The following is a description of a gene set: from publication Denning TL, Wang YC, Patel SR, Williams IR, Pulendran B (PMID 17873879) Human Gene Set: GSE8868_SPLEEN_VS_INTESTINE_CD11B_POS_CD11C_NEG_DC_UP species: Homo sapiens Genes up-regulated in dendritic cells (DC) from spleen versus those from intestine. The intestinal immune system must elicit robust immunity against harmful pathogens but restrain immune responses directed against commensal microbes and dietary antigens. The mechanisms that maintain this dichotomy are poorly understood. Here we describe a population of CD11b+F4/80+CD11c– macrophages in the lamina propria (LP) that express several anti-inflammatory molecules including interleukin 10 (IL-10), but little or no pro-inflammatory cytokines, even upon stimulation with Toll-like receptor (TLR) ligands. These macrophages induced, in a manner dependent on IL-10, retinoic acid and exogenous transforming growth factor-β, differentiation of FoxP3+ regulatory T cells. In contrast, LP CD11b+ dendritic cells elicited IL-17 production. This IL-17 production was suppressed by LP macrophages, indicating that a dynamic interplay between these subsets may influence the balance between immune activation and tolerance. Splenic or small intestine lamina propria CD11b+11c- cells were isolated for RNA extraction and hybridization on Affymetrix microarrays. We sought to determine the unique genetic profile of small intestine lamina propria CD11b+11c- cells., and this is the list of marker genes: RNF181, ATXN3, MCEMP1, B3GNT2, USP3, MFSD14A (major facilitator superfamily domain containing 14A), PGLYRP1, NAAA, KLHL25, RAB5IF, RALGAPB, C11orf68, TADA1, PRKAB1, RIOX1, CAP1, WAPL, AP1M1, FKBP1B, TBPL1, MARK2, JAZF1, GRINA, CCDC28B, SERTAD3, SYNE3, LFNG, TSTD1, RABIF (NCBI Gene Id 5877), SH3GL1, SGK3, SENP7, PCIF1, GABARAPL2, LTB, BCL11A, ZBTB39, G6PD, RNF31, NFAM1, DENND11, EVI5, THSD1 (NCBI Gene Id 55901), POR, BPIFB3, CCDC125, SLC9A1, FOXD2, ZNF746, STAT5A, CBX8, RAB29, USF3, SATB2, C6orf118, SDCCAG8 (NCBI Gene Id 10806), INTS5, ESRP2, PYGL (glycogen phosphorylase L), AGAP2 (ArfGAP with GTPase domain, ankyrin repeat and PH domain 2), SVIP, SULF2, IREB2, SPSB4, SLC15A4, COL8A2, TSEN34, SLMAP, DAAM1, ZC3HAV1, CCDC146, TENT4B, ZNF414, NLRP12, LDHB, CBFA2T3, FRAT1, INPP5B, TRIM34, SUN1, MOB3A, LY75, GIGYF2, ZYX, PKP3, DDX41, ZBTB42, TIAM1, TMEM40, DKK4, PCED1B, ATG4D, MFSD14B, NSD3, FBXO45, ARFIP1, UGP2, DYNLL1, RGS2, MFSD6, FAM53C, SLC22A15, CMC2, KCTD20, PHETA2, MYO1F, SIK1, GSKIP, RNF114, FLNA, SLC2A3, NFE2, PCOLCE2, WTAP, EPX, C5orf34, CSRNP2, SNRK, RGS3, F8A1, ZBTB9, UBA3, ABRAXAS2, ITGB7, CELSR3, KANK3, NOP53, BRD7, RIOK3, PDF, MCTP2, NSMCE4A, VPS13B, JAM3 (junctional adhesion molecule 3), KCTD11, PPP4R3B, STX16, PLIN5 (perilipin 5), GDPGP1, ICAM2, NFATC3, ATF7IP, PPP1R3D, CDC5L, COL9A3, BMS1, SOS2, RNF38, POLG2, KIF2A, AICDA, ZBTB2 (NCBI Gene Id 57621), FLII, CHST11, SWT1, FAM131B, CEBPD, CBX7, CORO1A, PAXX, UNC5C, BNIP3L, HECA, RAMAC, PIK3CD, RESF1, CD47, SMAD2, TOP3B, MON1B, SP3, USP18, ODF4, NEDD9, MED4, CSGALNACT2, NARF, CCDC126 (NCBI Gene Id 90693), SNX27, ACOT9, SIPA1L3, NAA35, YOD1, TMEM71, SOAT2, ARSB, NAA16, GRHPR, LINC00511, AQP9, PDIK1L, PUM1, MMP8, HOXB4, PPP2CB, TBC1D14, ARHGEF1, CTCF, KLHDC3, RAB33B